Given this list of marker genes Afap1, Elf1, Muc21, Mgat4d, Ncbp2, Psma6, Timm8a1, Slit2, Wnk1, Slc8a1, Frg2f1, Tfg, Nova1, Rnf19b, Pdss1, Nod1, Stim2, Dipk2b, Kdm3b, Dsc2 (NCBI Gene Id 13506), Arhgap21, Xrn2, Repin1, Zeb1, Qki, Cftr, Man1a2, Zscan26, Ptpn4, Ipo8, Arid2, Ankhd1, Tat, Nkapl, Ppat, Adamts3, Nit2, Neto2 (neuropilin (NRP) and tolloid (TLL)-like 2), Krtap9-3, Msn, Fermt2, Smarce1, Erbb4, Wrn, Ptprr, Onecut2, Eif5b, Slc4a10, Slfn14, Chd9, Mettl21a, Caprin1, Cadm2, Gk, Asap2, Vezf1, Col4a5, here is a description of the gene set: Mouse Gene Set: MIR_133A_5P Genes predicted to be targets of miRBase v22 microRNA mmu_miR_133a_5p in miRDB v6.0 with MirTarget v4 prediction scores > 80 (high confidence targets). from publication Chen Y, Wang X (PMID 31504780) studied in species Mus musculus